Given this list of marker genes Ighv6-4, Ighv5-12-4, Lyn, Ighv5-15, Igkv1-132, Ighv3-5, Ighv8-12, Ighv3-8, Ighv5-6, Shc1, Vav1, Fos, Ighv5-9-1, Igkv11-125, Igkv2-137, Igkv17-121, Plcg1, Ighv6-3, Iglc1, Igkv1-131, Igkv16-104, Rac1, Ighv5-17, Ighv8-8, Ms4a2, Lat, Ighv3-6, Igkv8-21, Sos1, Ighv3-1, Ighv8-9, Ighv6-6, Ighv8-13, Igkv1-110 (immunoglobulin kappa variable 1-110), Mapk9, Igll1, Iglc2, Vav2, Ighv8-4, Map2k7 (mitogen-activated protein kinase kinase 7), Jun, Igkv1-135, Ighv5-4, Mapk1, Ighv7-3, Ighv8-6, Kras, Igkv15-103 (NCBI Gene Id 692169), Ighv8-11 (NCBI Gene Id 636462), Grb2 (growth factor receptor bound protein 2), Ighv16-1, Grap2, Ighv12-3, Mapk10, Igkv1-99, Ighv7-2, Mapk8, Ighv5-9, Syk, Ighv5-12, Mapk3, Igkv2-109, Ighv3-4, Ighv3-3, Hras, Vav3, Ighv7-4, Igkv20-101-2, Igkv1-35, Igkv1-133, Plcg2, Ighv8-5, Ighv8-2, Ighv5-2, Ighv13-2, Ighv6-5, Ighe, Lcp2, Igkv18-36, Igkv1-117, Fcer1a, Fcer1g, Ighv6-7, Igkv1-122, Pak2, Igkv1-88, Ighv5-16, Pak1, Igkv2-112, Map2k4, here is a description of the gene set: FCERI mediated MAPK activation species: Mus musculus Mouse Gene Set: REACTOME_FCERI_MEDIATED_MAPK_ACTIVATION